Given this list of marker genes COX7A2, HMOX2, TGS1, FABP1, COX5A, COX4I1, ABCC1, COX6C, COX6A1, TXNIP (NCBI Gene Id 10628), HIGD1C, MED1, CREBBP, NLRP3, CHD9, HBA1, COX7C, NCOR2, TBL1X, BLVRB, HM13, MT-CO1, COX6A2, NFE2L2, RXRA, COX8C, PPARA, NCOA1, TBL1XR1, NCOA2, COX4I2, BLVRA, PTK6, NDUFA4, MAFK, HBB, COX5B, SMARCD3, NCOR1, STAP2, HDAC3, COX6B1, CYCS, COX7A2L, COX8A, STAT3, MT-CO3, SIN3B, COX7B, HELZ2, HMOX1, COX7A1, COX6B2 (NCBI Gene Id 125965), MT-CO2, BACH1, SIN3A, CARM1, NCOA6, HBA2, ALB, here is a description of the gene set: studied in species Homo sapiens Human Gene Set: REACTOME_CYTOPROTECTION_BY_HMOX1 Cytoprotection by HMOX1